The following is a description of a gene set: cNMP-dependent catalysis of the reaction: ATP + a protein = ADP + a phosphoprotein. species: Mus musculus Mouse Gene Set: GOMF_CYCLIC_NUCLEOTIDE_DEPENDENT_PROTEIN_KINASE_ACTIVITY, and this is the list of marker genes: Prkar2b, Pkia, Pkib, Nos2, Prkar2a, Prkag2, Prkx, Prkg2, Prkar1b, Prkacb, Prkg1, Prkaca, Smo, Prkar1a, Pkig